Given this list of marker genes LPIN1, STIM1, SARS2, ORAI1, LAMB2, ALG14, CHRNA1, CASQ1, OBSCN, MT-CO3, CNBP, CHRNE, SPTBN4, CHAT, MT-CO1, GFPT1, PNPT1, COLQ, here is a description of the gene set: Human Gene Set: HP_TYPE_2_MUSCLE_FIBER_ATROPHY studied in species Homo sapiens Atrophy (wasting) affecting primary type 2 muscle fibers. This feature in general can only be observed on muscle biopsy. Type 2 muscle fiber atrophy